Given this list of marker genes ARID2, SCGB1C1, NR3C2, EPRS1, GOLGA6D, FAM168B, GOLGA6B, GOLGA6A, PLAGL2, AMER2, CTTNBP2, GOLGA6C, SLC40A1, CUX2, here is a description of the gene set: species: Homo sapiens from publication Chen Y, Wang X (PMID 31504780) Genes predicted to be targets of miRBase v22 microRNA hsa-miR-553 in miRDB v6.0 with MirTarget v4 prediction scores > 80 (high confidence targets). Human Gene Set: MIR553